The following is a description of a gene set: studied in species Homo sapiens Human Gene Set: GOBP_PROTEIN_LOCALIZATION_TO_SITE_OF_DOUBLE_STRAND_BREAK Any process in which a protein is transported to, or maintained at, a region of a chromosome at which a DNA double-strand break has occurred., and this is the list of marker genes: IFFO1 (NCBI Gene Id 25900), HTATSF1, RAD17, CYREN, XRCC4, H2AX, TOPBP1, SIRT6, SLF2, MDC1, NBN, PARP3, RHNO1, TP53BP1, SLF1, RPA1 (NCBI Gene Id 6117)